The following is a description of a gene set: The directed movement of nucleoside across a membrane. Human Gene Set: GOBP_NUCLEOSIDE_TRANSMEMBRANE_TRANSPORT studied in species Homo sapiens, and this is the list of marker genes: SLC28A2, SLC29A1, SLC28A3, SLC29A3, SLC28A1, SLC29A4, SLC25A26, SLC29A2